The following is a description of a gene set: Any structural anomaly of the principal vein draining blood from the lower portion of the body. Abnormal inferior vena cava morphology Human Gene Set: HP_ABNORMAL_INFERIOR_VENA_CAVA_MORPHOLOGY species: Homo sapiens, and this is the list of marker genes: ACVR2B, SPEF2, ODAD3, CCDC39, STK36, LRRC56, OFD1, NEK10, RSPH4A, DNAJB13, NME5, HYDIN, FOXJ1, DNAH5 (NCBI Gene Id 64774), RSPH9, ODAD1, RSPH1, DNAAF4, GAS2L2, RSPH3, DNAL1, DNAAF5, MCIDAS, CFAP298, DNAAF2, DRC1, MMP21, KDM3B, CFAP74, ODAD2, RPGR, CFAP300, CFAP221, DNAI1, ODAD4, DNAAF11, DNAH11, DNAI2, DNAH9, CCNO, NME8, CCDC40, DNAAF1, ZMYND10, DNAAF3, TTC12, SPAG1, DNAH1, SMOC1 (NCBI Gene Id 64093), DNAAF6